The following is a description of a gene set: Any process that activates or increases the frequency, rate or extent of lysosome organization. studied in species Mus musculus Mouse Gene Set: GOBP_POSITIVE_REGULATION_OF_LYSOSOME_ORGANIZATION, and this is the list of marker genes: Ppp3cb, Irgm1, Irgm2, Igtp, Mcoln1, Grn